The following is a description of a gene set: Genes predicted to be targets of miRBase v22 microRNA hsa-miR-5006-3p in miRDB v6.0 with MirTarget v4 prediction scores > 80 (high confidence targets). from publication Chen Y, Wang X (PMID 31504780) studied in species Homo sapiens Human Gene Set: MIR5006_3P, and this is the list of marker genes: RPL17-C18orf32, FGFR2, USP14, KXD1, NAA40, PI4KB, BCL2, TMA16, EGFLAM, CDK12, PID1, EPHA5, ELAVL4, KLHL6, EFNA5, TENT5A, SIRT1, SLC7A14, SLC38A9, BIRC6, ZNF605, WDR36, MEIS2, MCOLN1, RETSAT, SGCD, ELF4, DTX4, HMGA2, TMEM64, AP3M1, HAS2, SDHD, CREB5, PTPRD, LARP4B, AK2, CALCRL, HAPLN1, UBA6, IGF2R, CHCT1, RUSC1, TMEM213, FGF18, MLLT3, CAMK2D, ATXN2, GSPT1, TUT4, KDM5A, ZNF300, ACADL, ODR4, BPNT2, DLG1, NRG3, PPARGC1A, SH3PXD2A, NRP1, TRIM44, WNT9B, SAMD5, CCDC117 (coiled-coil domain containing 117), LEPROT, SHC1, SZRD1, BMPR1A, SMIM13, AP1S2, FLT1, DAZL, TRPS1, ZNF740 (NCBI Gene Id 283337), HS6ST3, ITGB1, CELF2, ACSL4, TCF12, PREPL, RPRD2, EIF5, NUCKS1, ZBTB7C, SLC16A12, PTGR3, CACNA1C, C9orf40, RIN3, MOCS1, ALDH6A1, TUT7, PLXNA2, SH2B3, BCL11A, DNAAF9, SPOP, BCL2L2, PLCH1, CLN8, NR5A2, FMO5, CDYL2, ERC1, GOLGA5, LPP, ATL2, HAPSTR1, DNAJC13, CCNJ, KLF3 (KLF transcription factor 3), TMEM178B, SNX18, A2ML1, FBXL22, GNG12, GDF6, GABBR2, HOOK3, HCAR2, TMEM127, TSPAN13, RASL10A, MGAT3, ITPR1, HSPH1, PTPRR, TFAP2A, PEX19, UEVLD, ABRAXAS2, WWC3, ATP8A2, POU3F2, SLC28A3, WDR26, C1orf185, RINT1, GAD1, JARID2, ZBTB20, TRIM71 (tripartite motif containing 71), SEPTIN11, KCNMA1, TOX3, BICC1, PHOX2B, ESRRG, FAM13C, EDEM3, MPP7, EBF2, C2orf68, PTP4A1, IRF2BP2, DGKG, CDH11, CHN2, NIPA2, TGFBR2 (transforming growth factor beta receptor 2), C2orf76, ZNF704, RTL8B, SH3TC2, CCND1, IL11, RGL1, IRF2, RBM41, ARHGEF33, BCL7A, HOXD1, SPCS3, RTKN2, HNRNPUL1, EPHB1, NEXMIF, ONECUT2 (NCBI Gene Id 9480), SLITRK4, TXNDC5, RAB40B, SKI, KSR2, EPHA7, GCNT2, SOCS4, YPEL2, NXPH1, MAPK9, HNF4G, PPIC, ELAVL3, EPHB6, ROR1, LRP2, MRPS17, GNAQ, DPF1, C2CD2, RAB10, ARCN1, CIMAP2, GOSR2, YPEL4, VPS37B, FLVCR1, BHLHE22, IKZF2, TSPAN8, RHOBTB3, WDFY2, EPHB2, BIN1, PGGT1B (protein geranylgeranyltransferase type I subunit beta), TIFA, ANKRD13A, DR1, POLE3, RAB22A, MYCT1, ITIH5, GTF3C3, MTMR7, MTCL1, CTDSPL2, BPIFC, MAN2A2, KLHL29, INO80D, DVL3, TNRC6B, AHSA2P, ANO6, M6PR, CDKN2B, TAOK1, C14orf28, ANGPT1, FAM98B, HMGN4, SGIP1, SORT1, TOMM40L, MTMR12, RPS6KA5, MAPRE2, AMER1 (APC membrane recruitment protein 1), MAP3K2, ARL6IP5, RSPO4, CCNY, KLF11, AP2A2, ZNF266, ICE2, ZEB1, MLXIP, MYADML2, SEC61A2, EVC2, ZNF549, TENM1, SNAP47, CAPRIN1, HNRNPA2B1, KIF1B (NCBI Gene Id 57598), NAA15, RIMS2, C18orf32, PIAS1 (NCBI Gene Id 8695), CHD5, PROX1, MTCH2, ZC3H7A, ACVR2B, ARMC8, ZMYND8, TMEM135 (transmembrane protein 135), CCDC25, CNKSR3, NCOA7, BCL11B, SLC16A6, PLEKHM3, ADGRL3, N4BP2L1, ELAVL2, RNF169 (NCBI Gene Id 254225), NBR1, SUN1, NRBF2, TRIM2, ENTHD1, FOXC1, POM121, NTRK2, CLCN6, SEC24D, IL6R, JAK2, DCN, SASS6, SNX13, PTPRT, ZDHHC14, CTIF (NCBI Gene Id 9811), TET2, KCNK9, MINDY2, RAD21, CCDC120, BACE2, IPO8, PPP1R9A, PLXDC2, GLIS3, CAMK1D, IGFBP5, MON2, COX5A, STXBP5L, ACSM2A, LARP6, CENPA, EPHA4, TMOD3, CCND2, SLC19A2 (solute carrier family 19 member 2), ZCCHC24, FRMD4A, RFX7, RREB1, ZNF268 (zinc finger protein 268), LIG3, EZR, SPRY3, SLC37A3, ATP10B, FRAS1, B3GNT5, GPBP1L1, PDGFRB, ENTPD7, HYCC1, LSAMP, SAMD4A, MAP1B, AFAP1, FHIP1B, MMP16, RNLS, EFNB3, CES2, VWA8, ZNF148, CRACD (NCBI Gene Id 57482), GSTM3, FBN2, ATF2, UBR2 (NCBI Gene Id 255838), FUT9, FRS2, SOX14, IL33, DMTF1, PIK3CB